Given this list of marker genes Lin28b, Lin28a, Trub1, Bcdin3d, Dgcr8, here is a description of the gene set: species: Mus musculus Mouse Gene Set: GOBP_REGULATION_OF_PRE_MIRNA_PROCESSING Any process that modulates the frequency, rate or extent of pre-microRNA processing.